The following is a description of a gene set: studied in species Mus musculus A molecular adaptor that recognizes and binds a target protein containing a ubiquitin-like modification and that brings the target protein into contact with another protein to allow those proteins to function in a coordinated way. Mouse Gene Set: GOMF_UBIQUITIN_LIKE_PROTEIN_READER_ACTIVITY, and this is the list of marker genes: Saysd1, Pex1, Usp15, Jarid2, Ddrgk1, Ankrd13d, Dnajc2, Trp53bp1, Sqstm1, Hgs, Ccdc38, Uimc1, Pex6, Vcp, Rnf169, Ankrd13a, Ankrd13b, Stk38, Faap20 (NCBI Gene Id 67513), Fan1, Dnajb2